Given this list of marker genes GLYR1, INSR, ADAR, ITGB3, CDC14B, SLC35F2, CELF2, AIM2, SESN3, ANKRD6, DOCK8, HSH2D, TRPV2, IL31RA, TMEM106C, UGGT1, MARCKSL1, IFI44, PARP11 (NCBI Gene Id 57197), HAPSTR1 (NCBI Gene Id 29035), CDK6, LGALSL, SLC10A3, RTP4, IL10RB, CXCL6, FAM13B (NCBI Gene Id 51306), PNRC1, OAS2, CYBA (NCBI Gene Id 1535), CDKN1B, PLEK, SCGB1A1 (secretoglobin family 1A member 1), ANKRD50 (ankyrin repeat domain containing 50), RBM5, IRF7, SH3BGRL, SLC4A2, FLII, IWS1, CHD3, MYB, ARHGAP15, CHD9, PLCB1, ITGB2 (NCBI Gene Id 3689, integrin subunit beta 2), SMG6, ARMCX6, PABPC1 (NCBI Gene Id 26986), CDKN2C, PPT1, EBPL, CCDC25, RNASE6, DSP, TGFBR2, MORF4L1, RCN3, PTPRCAP (NCBI Gene Id 5790), TXNDC12, TASL, TNS1, LCP2, CHRNB1, TRPC6, PLAC8, ECSCR, CELSR1, TMEM263, FKBP7, IKZF1, UTRN, TPT1, HSPA2, LAIR1, ATP10D, C2CD3, HOXA9, EP300, AGO4, CNTLN, SUOX, IGKC, MEIS1, AMN1, RNASEL, CD84, RASA2, SLC24A3, NCOA1, PERP, FAM174B, REG4, F5, RGS18, POLR1H, CYLD, TMCC2, PPBP, IFI27, HELZ2, CASD1, FBXL12, IRF9, ADGRD1, CEP164, PLOD2, SERPINE2, TAGAP, SNORD89, RIPOR2, ACTG1, ARGLU1, DDX4 (NCBI Gene Id 54514), KLHDC1, THBS3, NCKAP1L, FYCO1, GCH1, SERPINB12, FAR1, CCNG2, S100PBP, CCPG1, HLA-E, STMN1, DUS4L, HOXA4, ATF7IP, ESYT1, GRAMD4, NUP210, RNF146, FLNA, KIAA0232, ECT2, OSBPL8, TOP3A, CEP68, STAG1, SPATA1, CPQ, PTGS1, DMXL2, SELENON, PBX1, ADPRM, FLOT1, TRIM5, NHSL2, SGPL1, KHDRBS3, TRIO, CSDE1 (cold shock domain containing E1), DHX58, PTPN22, TMEM98 (NCBI Gene Id 26022), TMCC3, ZNF600, PHF8, EVI2B, ALB, CCNI, IFIT1B, MSL2, EIF2AK4, CYLC2, LY96, GCA, ABCA2, ARMCX2, MED12L, ZNF518B, KLHL28, TSPAN13, PLPP2, MANBA, SELENOP, CDYL2, HNRNPK, FZD6 (frizzled class receptor 6), OSBPL9, CHST15, RAB37, PNPLA7, PCMTD1, TP53BP2, RSAD2, PLCB4 (NCBI Gene Id 5332), FIGNL1, TRIM14, SLC12A6, NME4, POLR3GL, CDH1, MFSD8, LRP10, KMT5B, EID2, CAPG, here is a description of the gene set: from publication Yusuf I, Kageyama R, Monticelli L, Johnston RJ, Ditoro D, Hansen K, Barnett B, Crotty S (PMID 20525889) Human Gene Set: GSE21380_NON_TFH_VS_TFH_CD4_TCELL_DN Genes down-regulated in CD4 T cells: non-Tfh versus Tfh (T follicular helper). species: Homo sapiens CD4 T cell help is critical for both the generation and maintenance of germinal centers, and T follicular helper (TFH) cells are the CD4 T cell subset required for this process. SAP (SH2D1A) expression in CD4 T cells is essential for germinal center development. However, SAP-deficient mice have only a moderate defect in TFH differentiation as defined by common TFH surface markers. CXCR5+ TFH cells are found within the germinal center as well as along the boundary regions of T/B cell zones. Here we show that germinal center associated T cells (GC TFH) can be identified by their co-expression of CXCR5 and the GL7 epitope, allowing for phenotypic and functional analysis of TFH and GC TFH populations. Here we show GC TFH are a functionally discrete subset of further polarized TFH cells, with enhanced B cell help capacity and a specialized ability to produce IL-4 in a TH2-independent manner. Strikingly, SAP-deficient mice have an absence of the GC TFH subset and SAP- TFH are defective in IL-4 and IL-21 production. We further demonstrate that SLAM (Slamf1, CD150), a surface receptor that utilizes SAP signaling, is specifically required for IL-4 production by GC TFH. GC TFH cells require IL-4 and IL-21 production for optimal help to B cells. These data illustrate complexities of SAP-dependent SLAM family receptor signaling, revealing a prominent role for SLAM receptor ligation in IL-4 production by germinal center CD4 T cells but not in TFH and GC TFH differentiation.